Given this list of marker genes ADH1C, ADH1A, ALDH1B1, ADH4, ALDH1A1, ACSS2, ADH5, ADH6, ADH7, ALDH2, ADH1B, ACSS1 (acyl-CoA synthetase short chain family member 1), here is a description of the gene set: Ethanol and related alcohols can be ingested as part of the diet and are formed by microorganisms in the intestinal tract. Ethanol oxidation to acetate occurs primarily in liver cells in a multistep process first described by Racker (1949). First, in the cytosol, ethanol is oxidized to acetaldehyde, with the formation of NADH. Second, in the mitochondrion, acetaldehyde is oxidized to acetate with the formation of NADH. Finally, acetate in the mitochondrion can be condensed with coenzyme A to form acetyl CoA. Polymorphisms in the enzymes catalyzing the first two steps are associated with variation in the efficiency of alcohol catabolism in human populations. The molecular mechanism by which cytosolic acetaldehyde enters the mitochondrial matrix is not known.<p>Cytosolic enzymes capable of oxidizing acetaldehyde to acetate have also been identified and characterized in vitro so a purely cytosolic pathway for ethanol oxidation to acetate and conversion to acetyl-CoA can be annotated. The role of this pathway in vivo is unclear, though limited attempts to correlate deficiencies in the cytosolic enzyme with alcohol intolerance have yielded suggestive data. Additional peroxisomal and microsomal pathways for the oxidation of ethanol to acetaldehyde have been described; their physiological significance is unclear and they are not annotated here. part of: Phase I - Functionalization of compounds studied in species Homo sapiens Reactome Pathway: Ethanol oxidation